Given this list of marker genes Edem1, Eif4a1, Lifr, Znrf3, Asb1, Speg, Bhlhe41, Stxbp4, Sin3a, Gtpbp2, Endou, Zeb1, Agap1, Ogt, Napepld, Acvr2a, Ptger3, Tmem121b, Zfp512b, Zfp169, Cdk5r1, Ddx42, Ces1g, Abca9, Sgcz, Inpp5a, Xpo7, Plcb1, Fam117b, Pou2f1, Apc, Ndc1, Zfp281, Efemp2, Cep97, Zmym4, Mdm1, Macrod2, Pcdh19, Tub, Magi1, Cmtm3, Gbp5, Tfap4, Srsf1, Ccnc, Scn2b, Sbds, Xirp2, Plin4, Ppp1r8, Zfp395, Synj2bp, Dnaaf9, Kmt2a, Kpna4, Rabep1 (NCBI Gene Id 54189), Pi4k2a, Get4, Ap4e1, Gm5878, Trpc5, Csmd1, Nfib, Prss59, Tmem39a, Zfp781a, Prpf39, Bhlhe40, Edn1, Dusp6, Mapk14, here is a description of the gene set: from publication Chen Y, Wang X (PMID 31504780) studied in species Mus musculus Genes predicted to be targets of miRBase v22 microRNA mmu_miR_6976_3p in miRDB v6.0 with MirTarget v4 prediction scores > 80 (high confidence targets). Mouse Gene Set: MIR_6976_3P